Given this list of marker genes NCOR1 (NCBI Gene Id 9611), MED14, BRAF, SNRNP200, PTGDR2, KLRA1P, SLC25A22, SH3TC1, AEN, EAF1, PARP16, MARCHF6, MICAL3, RLF, TAGAP (NCBI Gene Id 94011), TACC1, SMC5, SIDT2, HOXA7, GLCCI1, PPP4R3B, KBTBD8, NOX4, STARD4, MUS81, WSB1, RAB8B, CRKL (CRK like proto-oncogene, adaptor protein), NFATC1, AGO2, DBF4, ARL8B, UBR7, SH3BGRL (SH3 domain binding glutamate rich protein like), OPA1, INTS7, LIPA, MDM2, TAF1D, MIOS, LBR, NMD3, SEC16A, DNAJC5B, APOA2, RBBP6, DDX49, ALCAM, KLHL15, FYTTD1, PKD1, PIP5K1A, DHX15, ZHX2, DCLRE1C, PURA, AKR1D1, C1orf159, NRAS, PTPN11, SBNO1, TUG1, RNGTT, PPTC7, CREBZF, A1CF, VPS35L, HLA-DRB3, NSUN2, ZMIZ2, WDR75, FEM1A (fem-1 homolog A), USP25, PIBF1, NUP205, BNIP3, BET1L, THOC7, PELI1, PRKCI, PUM2, SGCD, TLE4, CRIP2 (cysteine rich protein 2), DNAJA3 (DnaJ heat shock protein family (Hsp40) member A3), ANKRD20A1, GTPBP1, C2CD5, SP1, STK4, SEC24C, STK10, EIF2AK3, CD164, NFYA, DMD, KLF10, PMAIP1, SCYL2, G3BP2 (NCBI Gene Id 9908), here is a description of the gene set: Human Gene Set: MODULE_182 Genes in the cancer module 182. species: Homo sapiens